The following is a description of a gene set: Binding to the oxidized form, FAD, of flavin-adenine dinucleotide, the coenzyme or the prosthetic group of various flavoprotein oxidoreductase enzymes. Human Gene Set: GOMF_FAD_BINDING species: Homo sapiens, and this is the list of marker genes: DDO, MICAL1, CYB5R3, AIFM1, NQO2, PCYOX1, ERO1B, STEAP3, DHCR24, MMACHC, CYBB, ACOX2, LDHD, CYB5R1, ERO1A, CRY2, XDH, MTHFR, AOX1, AGPS, PRODH (NCBI Gene Id 9539), CYB5R2, KMO, SQLE, PRODH2, COQ6, MTRR, CRY1, DAO (NCBI Gene Id 1610), TXNRD1, ACOXL, MICAL3, STEAP4, KDM1B, ACOX1, SQOR, MICAL2, QSOX1, D2HGDH, ACOX3, NDOR1